The following is a description of a gene set: species: Mus musculus The selective degradation of lipid droplets by macroautophagy. Mouse Gene Set: GOBP_LIPOPHAGY, and this is the list of marker genes: Rab7, Spart, Aup1, Adrb2, Sptlc1, Sesn2, Sptlc2, Htt (huntingtin)